The following is a description of a gene set: species: Homo sapiens Using a target gene approach, only a few host genetic risk factors for treatment-related myeloid leukemia (t-ML) have been defined. Gene expression microarrays allow for a more genome-wide approach to assess possible genetic risk factors for t-ML. We assessed gene expression profiles (n=12 625 probe sets) in diagnostic acute lymphoblastic leukemic cells from 228 children treated on protocols that included leukemogenic agents such as etoposide, 13 of whom developed t-ML. Expression of 68 probes, corresponding to genes, was significantly related to risk of t-ML. Hierarchical clustering of these probe sets clustered patients into three groups with 94, 122 and 12 patients, respectively; 12 of the 13 patients who went on to develop t-ML were overrepresented in the latter group (P<0.0001). A permutation test indicated a low likelihood that these probe sets and clusters were obtained by chance (P<0.001). Distinguishing genes included transcription-related oncogenes (v-Myb, Pax-5), cyclins (CCNG1, CCNG2 and CCND1) and histone HIST1H4C. Common transcription factor recognition elements among similarly up- or downregulated genes included several involved in hematopoietic differentiation or leukemogenesis (Maz, PU.1, ARNT). This approach has identified several genes whose expression distinguishes patients at risk of t-ML, and suggests targets for assessing germline predisposition to leukemogenesis. Human Gene Set: BOGNI_TREATMENT_RELATED_MYELOID_LEUKEMIA_UP from publication Bogni A, Cheng C, Liu W, Yang W, Pfeffer J, Mukatira S, French D, Downing JR, Pui CH, Relling MV (PMID 16341039) Genes up-regulated in ALL (acute lymphoblastic leukemia) patients who developed t-ML (treatment related myeloid leukemia)., and this is the list of marker genes: ATF6B, RFNG, IZUMO4 (IZUMO family member 4), SLC10A1, PAX5, FMO6P, NPR2, SLC25A6, PGK1, H4C3, FLNA, SEMA6C, S100A2, ZKSCAN5, POLR2A, RPL17, DNAJA2, KLRC1, CLPP, SGPL1, MAP2K1, EFEMP1, CFP, GABRB1, CXCR1 (C-X-C motif chemokine receptor 1), EPB41, RPS27A, HP, RPL11, EFNA2, MPST